The following is a description of a gene set: studied in species Mus musculus Mouse Gene Set: GOBP_NEGATIVE_REGULATION_OF_ALCOHOL_BIOSYNTHETIC_PROCESS Any process that stops, prevents or reduces the frequency, rate or extent of alcohol biosynthetic process., and this is the list of marker genes: Nfkb1, Rest, Apoe, Cyp27b1, Bmp2, Gfi1, 3110082I17Rik, Isyna1, Erlin2, Plek, Insig1, Bmp5, Idi2, Erlin1, Prkg1, Dkk3, Sod1